The following is a description of a gene set: studied in species Mus musculus Mouse Gene Set: GOBP_EMBRYONIC_DIGESTIVE_TRACT_MORPHOGENESIS The process in which the anatomical structures of the digestive tract are generated and organized during embryonic development. The digestive tract is the anatomical structure through which food passes and is processed., and this is the list of marker genes: Tcf7l2, Pitx2, Foxf1, Id2, Pdgfra, Shh, Six2, Tcf21, Hnf1b, Shox2, Fgf10, Sox11, Ovol2, Gli3, Gata4, Ihh, Tcf7, Nipbl, Rbpms2, Fgfr2, Hlx